Given this list of marker genes KRTDAP, SACM1L, KLHL14, KCNAB1, ARL13B, PRPS2, MYF5 (myogenic factor 5), ATP1B4 (NCBI Gene Id 23439), PHC3, CCDC141, DCAF10, KRTAP19-3, NPTN, LUM, LEMD3, ZMYM3 (NCBI Gene Id 9203), MORC1, NDFIP2, RFX7, SPIN1, PLPP3, COBL, CHL1, TMPO, ANKRD12, CFAP44, AGGF1, OLA1, DDIT4L, SEMA3A, NRP2, CRISPLD1, RAB38, LGSN, FNDC3A, RIMKLB (ribosomal modification protein rimK like family member B), APOBEC4, SLC17A6, CFAP300, HIPK3, KCNT2 (potassium sodium-activated channel subfamily T member 2), TNRC6B, ZNF716, NEMP1, ENPP1, DST, CLIC2, CYP20A1, KIAA1210, ENPP4, IL2, HAND1, ERICH3, ZNF333, LIN7A, SLC17A2, NEDD1 (NCBI Gene Id 4732), PHACTR1, PMS1, AURKA, POLI, NIPA1, ZNF451, MRO, G3BP2, CTNNA3, CD47, ZNF197, HACD3, C22orf23, TMOD2, HNRNPR, SETBP1, NAALADL2, COX20, SVIL, TAS2R13, CFAP69, PRTG (NCBI Gene Id 650816), SCAI, ARFGEF1, FLVCR2, WASHC4, LINGO2, EFR3A, MANEA, KMT5B, EFCAB2, HOXA4 (homeobox A4), GRIA2, WDFY1, UTY, LIN7C, DCLK1, RAB33B, TFAM, CTBS, LPGAT1, GCM1, SEPTIN2, ATRNL1, MARCHF6, FKTN, IFIT2 (interferon induced protein with tetratricopeptide repeats 2), ZDHHC20, SYT14, PCDH9, TRAM1, LIN54, DDHD2, GPD2, HSPA12B, ENOPH1, ROCK1, SETD9, MPLKIP, LCORL, G2E3, GNRHR, HOOK3 (hook microtubule tethering protein 3), ASPH, E2F5, HECTD1, PABPC1, NOP14, CA2, ATP11C, ZNF292, GPR158, F2R, ELOVL5, CRH, BBX, ZMYND11, MAGEA9, RNF6, ZNF418, CNOT7, PTGER4, DCBLD2, TRIM71, PPP1R21, RYK, BCL2, GPR85, FUT9, KDM4C, PIK3R2, NEXMIF, CALHM4, ROR1, ARMCX3, TMEM267, PRR27, RGCC, TMEM64, MLF1, JMJD1C, RNF170, ASCC1, TOR1AIP2, PRDX3, POF1B, BRK1, COL15A1, TBX4, CD83, SLC12A4, ABCA5, CGGBP1, SNTG1, CERT1, SRSF2, OTUD4, LRRC39, UQCRC2, RBBP9, EIF4E2, PYROXD1, DNMT3A, CCDC162P, DYRK2, HIVEP2, ERGIC2, EML5, PTPN4, RPS6KA6 (NCBI Gene Id 27330), FAM76A, GLIPR1, BMPR1B, DCDC2, GPALPP1, TCEA1, RND3, AFG2A, DEPDC1, PTP4A2, PNISR, ELAPOR1, FBXO22, WWP2, GABRA4, SLC7A13, SLC35A5, SCG3, POU4F1, EIF5AL1, ROBO1, MEGF11, PPP4R2, PLEKHG1, ARHGEF3, AQP4, HNRNPUL2, OSBPL3, SEPTIN10, NOX4 (NCBI Gene Id 50507), PTPRK, ZNF518A, CADM2, ARHGAP24, ZNF100, MYB, TMEM87B, SHISA9, WAPL, PPM1K, PET117, EPHA3, PPP4R4, DAPP1 (dual adaptor of phosphotyrosine and 3-phosphoinositides 1), IAPP, NUDT12, SSH1, USO1, ZFAND3, TEX55, SLC6A19, UBQLN1, CRLS1, CGNL1, RBM12B, ZNF516, MYO1D, C1QTNF3, IPO8, ZNF30, RNF217, MSI2, RLIG1, EIF3M, ZNF99, BCAT1, PRG4, SPATA13, HDAC8, ABCD2, CTDSPL, MAGOHB, KLF12, HMX2, ARRDC4, GJA1 (NCBI Gene Id 7953), SMLR1, CDS2, CLDN16, PSD2, CLEC19A, TMEM106B, PARD3B, PLEKHH2, EPCAM, HSPA8, DICER1, AVL9, HNRNPLL, CANX, FXR1, SLURP1, PTPRJ, SAMD9, MBNL2, PDSS2, MTX3, RIC8B, GSN, PROKR2, LRAT, CAAP1, NTRK2, ATP6AP2, TRPC1, MEGF9, TMEM117, UPRT, CCR3, TDRP, IDS, ANTXR2, VPS37A (VPS37A subunit of ESCRT-I), MDN1, TRIO, CSN2, EGLN1, MKX (mohawk homeobox), SAMD8 (NCBI Gene Id 142891), CIAO2A, SUV39H2, INO80D, PPHLN1, BTNL9, AGK, PDE4D, SIM1, CAV2, WNT11, DMRT3, ZNF92, SNW1, PDS5B, CPT1A, ENAH, IPO7, TMEM161B, SPP1, LRRTM4, PBX1, MCM10, CCBE1, DGKH, KCNQ3, WDR27, TLR3, ARHGAP15, EPHA5, PRMT6, YAF2, C7orf57, ADGRL2, METTL16, MASTL, NOX1, COL5A2 (NCBI Gene Id 1290), CHORDC1, UBA6, KCNH5, CACNB4, NRXN1, CLOCK, FUCA2, KCND2, GRID2, CNST (consortin, connexin sorting protein), EFNA1, MEI4, SLAIN2, SIX6, OLIG1, MRPL19, BEND6, LIN28B, ERLIN2, HERC2, COL25A1, RAD51B, ALB, B3GALT2, CEP162, MPZL1, ASPM, FGF5, DCTN4, LHFPL6, C1GALT1, STAM2, LSM6 (LSM6 homolog, U6 small nuclear RNA and mRNA degradation associated), RUNDC3B, RGPD1, NAPEPLD, NDUFA9, MOSPD2, SLC25A21, KALRN, VAMP4, RICTOR, TENM1, AGAP1, STK32C, TTC6 (tetratricopeptide repeat domain 6), EMC4, CFAP97D1, SNCAIP, ZNF277, GIT2, STXBP5, LRRC58, SPPL2A, NPFFR2, CMTM6, PHACTR2, SMIM15, SNRPD1, PCDH17, GNG2, PLXDC2, VPS29, EDAR, AMTN, TMEM170B, TEX2, ZDHHC21, CCND1 (NCBI Gene Id 893), NAA16, ZEB2, CSNK1A1, DNAJB6, ACAP2, RGL1, SEC62, GEM, GPR18, GDAP2, PTBP3, SLC2A12, KLHL15 (kelch like family member 15), LIMS1, LRP6, TMEFF2, SFMBT1, GCNT2, DMRTA1, SELENOF, PHTF2, C2orf78, TLR2, ALG13, here is a description of the gene set: Human Gene Set: MIR4307 Genes predicted to be targets of miRBase v22 microRNA hsa-miR-4307 in miRDB v6.0 with MirTarget v4 prediction scores > 80 (high confidence targets). species: Homo sapiens from publication Chen Y, Wang X (PMID 31504780)